The following is a description of a gene set: studied in species Homo sapiens Genes down-regulated in comparison of naive CD8 T cells versus effector CD8 T cells KLRG1 Int. Using killer cell lectin-like receptor G1 as a marker to distinguish terminal effector cells from memory precursors, we found that despite their diverse cell fates both subsets possessed remarkably similar gene expression profiles and functioned as equally potent killer cells. However, only the memory precursors were capable of making IL-2 thus defining a novel effector cell that was cytotoxic, expressed granzyme B, and produced inflammatory cytokines in addition to IL-2. This effector population then differentiated into long-lived protective memory T cells capable of self-renewal and rapid re-call responses. Mechanistic studies showed that cells that continued to receive antigenic stimulation during the later stages of infection were more likely to become terminal effectors. Importantly, curtailing antigenic stimulation towards the tail-end of the acute infection enhanced the generation of memory cells. These studies support the decreasing potential model of memory differentiation and show that the duration of antigenic stimulation is a critical regulator of memory formation Human Gene Set: GSE10239_NAIVE_VS_KLRG1INT_EFF_CD8_TCELL_DN from publication Sarkar S, Kalia V, Haining WN, Konieczny BT, Subramaniam S, Ahmed R (PMID 18316415), and this is the list of marker genes: SLC35D1, SERPINB6 (NCBI Gene Id 5269), PROX1, EHD4, SRCIN1, NECAB3, HAUS1, NDUFS3, TEX30, LGALS2, GEMIN6, C17orf75, RAB34, NME1, AKAP1, GEM, SKA3, CYFIP1 (cytoplasmic FMR1 interacting protein 1), CMC2, TUBB4B, ANXA2, ANLN, GZMA, SGCB, PSMB2, PSMD13, PLP2, FAM185A, MAD2L1, DPY30, PRC1, NDE1, GLDC, PLSCR1 (phospholipid scramblase 1), NMNAT1, MBNL3, RPS27L (ribosomal protein S27 like), BANF1, TBRG4 (NCBI Gene Id 9238), ATP5MC1, CENPH (NCBI Gene Id 64946), MRPS18C, MRPS22, NUPR1, SCN8A, LRRC3B, ENDOD1, MRPL35, PDSS2, LHPP, MPV17L, PLIN2 (NCBI Gene Id 123, perilipin 2), ARHGAP19, PRDM1, CYP51A1, SMIM3, CDKN1A, SLC25A24 (solute carrier family 25 member 24), CSRP2, TMCO1, TACC3, CMSS1, CKS1B, ALG6, CHCHD10, LGALS1, PIF1, GTF3A, RFC5 (NCBI Gene Id 5985), SERPINB9, RAD54L, TATDN2, SLC15A3, HOXC4, PPIL1, SOAT2, NAA20, SYCE2, FAM110A, CASP7, CCR5, LENEP, ARHGEF28, HNF1B, LZIC, NEO1, YIF1B, INCENP, ATP12A, UCHL3, KIF22 (NCBI Gene Id 728037), BARD1, RPS19BP1, AIMP2, SNRNP40, MARVELD2, PLK4, KIF18B, TRIM37, PIK3AP1, SLAMF7 (SLAM family member 7), ZMYM3, MLEC, FAAP24, RHBDF2, ALYREF, POLE, ATP5IF1, CISD3, ALAD, GABPB1, PDCD5, NXT1, RFWD3, B4GALT5, GNPDA1, SCCPDH, PRKRIP1, TNFRSF1B, LGALS3, GZMK, DIP2A, GSTO1, SNX10, RAD51, CLHC1, CENPS, STARD8, PALS2, MRPS10, IRF8, HMBS, PSMD9, MRPL15 (mitochondrial ribosomal protein L15), RHOQ, LAMA5, SKIC8, WEE1, E2F8, HASPIN, FKBP1A, LSS, USP46 (ubiquitin specific peptidase 46), TIGAR, AURKB, NUDT5, ZFPM1 (NCBI Gene Id 161884), FOXK2, LIG1, MALSU1, NDUFAF5, UMPS, SLC43A3, HLA-A, DHFR, CIP2A, COPS4, KIF11, RFC2, ASRGL1, NEK2, LRP8, RAD51C, CCNE1, ZCCHC4, CCNA2, PBK, MPZL3, STXBP6, STMN1, ETFB, MTFR2, TSPAN33, ZNF503, SLC1A4, RANBP1, RAPH1, CENPP, ZNHIT3, AP3S1, TMEM163, MICAL2, PDILT, TOX2, MRPS28, EME1, ZFAND4, TYMS, CHEK1, FLT4 (NCBI Gene Id 7909), TIAM1, MAPRE2, POLA2, UNC119, SDCBP2, GRB7, DECR1, ALDH7A1, ARL6, DBF4